The following is a description of a gene set: Human Gene Set: MIR519A_3P_MIR519B_3P Genes predicted to be targets of miRBase v22 microRNA hsa-miR-519a-3p, hsa-miR-519b-3p in miRDB v6.0 with MirTarget v4 prediction scores > 80 (high confidence targets). from publication Chen Y, Wang X (PMID 31504780) species: Homo sapiens, and this is the list of marker genes: DCBLD2, ZNF367, HIF1AN, ZNF704, NEUROG1, PHC3, CMPK1, SYDE2, ITCH, CYP4V2, BMPR2, MYRF, MYBL1, HYCC2, SRGAP1, USP3, SPOPL, JAK1, TAOK1, BTBD7, RPS6KA5, EREG, NR2C2, NRSN1, FBXO48, RXFP1, PHF14 (NCBI Gene Id 9678), FAM199X, SH3PXD2A, FMR1, CHRM2, PHKA1, DYNC1LI2, CDC37L1, ARID4B, DENND10, MAPRE1, MAN1C1, ACSL4, GJA1, IRF2, PRKAA1, SKIDA1, NAA50, CEP164, RAB5C, MAP1B, MYT1L, NELL2, SLAIN1, PXK, SOCS6, PIGA, IKZF2, BECN1, BAG5, ARHGAP12, SACS, MBNL1, FBXW11, ZFHX4, SCN2B, PCDHB4, AGO1, VASH2, GPR137C, KCNK10 (potassium two pore domain channel subfamily K member 10), ANKRD29, DNAL1, USP28, ADIPOR2, FZD6, CR2, CHD5, HAS3, NABP1, E2F1, KIF23, MAP7, TRIP10, ZBTB18, HIF1A, MEX3D, LPGAT1, RORB, PARP1, REPS2, FIBIN, CBX6, WDFY3, MAB21L1, KIF13A, KBTBD2, ESR1, ATXN7L1, ACTL6A, MIER3, RASD1, CHD9, FILIP1L, HSPA8 (heat shock protein family A (Hsp70) member 8), CPEB1, DNAJC16, DLG5 (discs large MAGUK scaffold protein 5), CREBRF, USP32, CAMSAP2, JAKMIP1, TMEM50B, ATXN1L, FAM78A, IRF2BP2, TLX1, TFAP4, SATB2, RASGEF1A, TP63, STXBP5, ZFP91, HMGB3, MAP3K8, HABP4, TNFRSF21, CLCN3 (NCBI Gene Id 133073), STX6, ARX, INTS6, TCIM, KLHL28 (NCBI Gene Id 54813), GUCY1A1, PPP1R9A, EMSY, NKIRAS1, MASTL, PDE3B, SLC24A2, ITGB4, BRWD1, IGF1 (insulin like growth factor 1), ERCC4, NALF1, IL1RAP, CENPO, IQCH, SCUBE3, RPRD2 (regulation of nuclear pre-mRNA domain containing 2), CTSK, SON, TAPT1, ABL2, LCLAT1, CRY2, PLIN2, SNRK, CUL3, CREB5, GALNT13, BNC1, NAGK, MYLK, WDR33, SMOC1, CREB1, NMUR2, SAMD8, EIF4G2, HNRNPUL1, ASXL2, BTBD10, ZNRF3, KBTBD8, LATS2, ACVR1, PRDM8, GPR158, PKD2, TOPORS, POLQ, TGFBR2, NPAS2, EZH1, NRP2, CCDC88A, PPP1R3B, ILF3, PITPNA, ZNFX1, EMX2, DCAF8, PROX1, TNKS1BP1, CFL2, DNAJB9, AAK1 (NCBI Gene Id 652453), KREMEN1, ZNF217, MAPK4, VLDLR, PGM2L1, FBXL5, GRIN2A, APCDD1, ANKRD13C, GDA, FBXL17, L3MBTL3, RUBCN, CEP120, UHRF2, BTG3, SLC35D1, MBNL3, CRISPLD1, SOBP, LIMK1, CDADC1, WDR20, ATP6V1C1, KMT2A, BLCAP, SLC40A1, TMEM170B, FCHO2 (FCH and mu domain containing endocytic adaptor 2), ANKFY1, IFNAR2, GAB1, PRR15, AFG1L, RNF128, ENPP5 (ectonucleotide pyrophosphatase/phosphodiesterase family member 5), PTHLH, PDZD11, HPS5, FAM117B, PTPN4, PRDM16, R3HDM1, SFRP4, GRM5, NFIA, RAP2C, ZFAND4, OTUD7B, MIGA2, CPEB3, PXYLP1, ARHGAP29, ZFYVE9, E2F2, NIN, TEX2, CEP97, ZHX2, CDK2, GOLGA1, SFMBT1, RAB8A, PHTF2, UBE3A, MOSMO, STXBP5L, LRIG1, YTHDF2, STK17B, KCND2, PLCB1 (NCBI Gene Id 23236), ZNF236, FJX1, MYOCD, BCO1, KDM2A, NACC2, PIGS, HECA, TOX3 (TOX high mobility group box family member 3), MAP3K12, GRB10 (growth factor receptor bound protein 10), TMOD2 (NCBI Gene Id 29767), CASD1 (NCBI Gene Id 85885), KMT2B, SMAD5, HOXA3, SAMTOR, SLC17A6, ZNF652, KCNA1, EPHA4, NHLH2, ARHGAP24, FOXF2, ZBTB4, TRERF1, FRMD6 (FERM domain containing 6), ATG16L1, CPA3, ARHGAP1 (NCBI Gene Id 392), ATP12A, DIP2A, LIMA1, CNOT6, PAFAH1B1, PDCD1LG2, CNOT7, ZNF711, TMEM168, KRT23, ZBTB5, CIT, HAS2, RUFY2, MAPK1, LARP4, ELK3, ABRAXAS2, TSEN34, FYCO1, RASL11B, HFM1, FAM169A, NUFIP2, ARID4A, SGMS1, HS3ST5, SNX5, SETD5, HEG1, BTF3L4, TMEM64, HSD17B11, SPTY2D1, NAA30, SMYD2, RACGAP1, TAFA1, TESK2, MDM4 (NCBI Gene Id 4194), CAPRIN2, INSYN2B, ERBIN, HIVEP2, SUV39H1, EFR3A, FASTK, RAPGEF4, GABRR1, ANKIB1, SORL1, NFIB, KLHL20, SNIP1, SEMA7A, RTN1, PIK3AP1, IER3IP1 (immediate early response 3 interacting protein 1), PPP6R2, ZDHHC14 (zinc finger DHHC-type palmitoyltransferase 14), LAPTM4A, COA1, USP31, NCKAP5, TIPARP, EIF4E2, EFNA5, PSD, ARHGEF11, SALL3, MOB1B, MAP3K2, RAD51B, TANC2, HBP1, ARAP2, BICD2, ZNF250, MAP3K9, USP6, E2F7, SOS1, RNF216, ABHD3, PPP1R15B, FSTL5, STX12 (syntaxin 12), DPYSL2, ROCK2, CNOT4, ITPR1, LMX1A, TFCP2L1, ITPRIPL2, MTMR4, KCNJ10, SSH1, FANCM, LRP4, ATP2C1, LDLR, FOXJ3, PIKFYVE, TSG101, MRRF, ENTPD4, UXS1